Given this list of marker genes Elovl4, Ggt1, Fh1, Sirt3, Cebpa, Gcdh, Elovl5, Pdhx, Bckdk, Elovl6, Pam, Acat1, Casp1 (caspase 1), Degs1l, Gba1, Nanp, Ggt6, P2rx7, Asah2, Nans, Abca8a, Cers1, St3gal2, Ggt5, Abca8b, Nags, Coasy, Bloc1s6, Cps1, Acsl4, Arg1, St8sia6, Gzmb, B4galnt1, Acsl1 (NCBI Gene Id 56355), Cers3, Ppcdc, Pank3, Asah1, Pgk1, Snca, B4galt4, Ugt8a, Slc1a1, Pank4, Ormdl3, B3galt2, Cers5 (NCBI Gene Id 71949), Gsdmd, Smpd4, Mecr, Mmut, Ppcs, Arg2, St8sia3, Ccn1, Prf1, Acaca, Nfe2l2, Hagh, St6galnac4, Paqr4, B4galt6, Sptssb, Gclc, Dcakd, Elovl3, St6galnac3, Acly, Acss1 (NCBI Gene Id 99069), Dlat, Slc25a42, Sphk2, Acot7, Pnpla1, Elovl7 (ELOVL fatty acid elongase 7), Pdk3, Slc25a16, Mmaa, Degs2, Smpd1, Otc, Smpd3, Tpk1 (thiamine pyrophosphokinase), Acacb, St3gal3, P2rx1, Mpc2, Htt, Cyp4f39 (NCBI Gene Id 320997), Agk, Pdk2, Pemt, Slc7a11, B3galt4, Zfp750, Gal3st1, Tlcd3b, Pm20d1 (peptidase M20 domain containing 1), Vdac1, Samd8, Vapa, Pdhb, Ggt7, Alox12b, Acsl6, Asns, Mpc1, Ormdl1, Pdha1, Pla2g6, Pank2, Smpd2, Degs1, Pank1, Smpd5, Casp7, Mgst2, Agmat, Osbp, Cers4, Eif2ak3, Sgms1, Acsl5, Cers2, Ass1, Sphk1, Klk1b1, Ormdl2, 6430550D23Rik, Pdk1, B4galt3, Ugcg, Sgms2, St6galnac5, St8sia4, Slc1a2, Sptlc3, Mlycd, St8sia2, Prkcd, Sptlc1, Enpp7, Sptlc2, Asmt, Dld, St6galnac1, Dip2a, Cers6, Gss, Sptssa, Elovl1, Aloxe3, Cryaa, Asl, Gclm (NCBI Gene Id 99692), St6galnac6 (ST6 (alpha-N-acetyl-neuraminyl-2,3-beta-galactosyl-1,3)-N-acetylgalactosaminide alpha-2,6-sialyltransferase 6), Pdk4, Gm6993, B4galt5, Pdha2, St3gal1, Fa2h, Carns1, Acss2, B3galt1, Aanat, Gne, here is a description of the gene set: Mouse Gene Set: GOBP_AMIDE_BIOSYNTHETIC_PROCESS The chemical reactions and pathways resulting in the formation of an amide, any derivative of an oxoacid in which an acidic hydroxy group has been replaced by an amino or substituted amino group. species: Mus musculus